The following is a description of a gene set: studied in species Mus musculus The regulated release of any corticosteroid hormone into the circulatory system. Mouse Gene Set: GOBP_CORTICOSTEROID_HORMONE_SECRETION, and this is the list of marker genes: Wnk4, Kcnk9, Nrg1, Tac1, Ptpn11, Pomc, Ren1, Agt, Agtr1a, Bmp6, Selenom (selenoprotein M), Crh, Cry2, Gal, C1qtnf1, Kcnq1, Agtr2, Cry1, Ghrl, Crhr1, Ecrg4, Tspo, Galr1, Dab2